The following is a description of a gene set: A protein complex produced by sequentially activated components of the complement cascade inserted into a target cell membrane and forming a pore leading to cell lysis via ion and water flow. studied in species Homo sapiens Human Gene Set: GOCC_MEMBRANE_ATTACK_COMPLEX, and this is the list of marker genes: C9, C8G, C5, C8B, C6, C7, C8A